The following is a description of a gene set: Human Gene Set: HP_HEPATIC_CALCIFICATION species: Homo sapiens The presence of abnormal calcium deposition in the liver. Hepatic calcification, and this is the list of marker genes: ABCC6, CPT2, LYN, ENPP1, LBR